Given this list of marker genes PIP4K2B, NES, CALD1, E2F7, TRAPPC2, ZPLD1, NUDT7, ATP11C, POLR3F (RNA polymerase III subunit F), TARDBP, SYNJ2BP, KHDC4, ZNF423, NHEJ1, ACSL6, SLC25A5, PAFAH2, BCL11A, SLC9A7, RTKN2, RETREG1 (NCBI Gene Id 96119), GTF2IRD2, P2RY10, CSMD2, MXRA5 (NCBI Gene Id 91006, matrix remodeling associated 5), EPHA6, ANLN, AGFG1, DENND6A, IP6K3, FAM168B, NCAM1, CHRNE, JARID2, SNX27, TRAK1 (NCBI Gene Id 22906), AFF3, CDC14A, RAB37, ELOC, ZFAND5, OGG1, OCM, DCLK1, NLGN1, SLC38A2 (solute carrier family 38 member 2), SHROOM1, C5orf24, GID8, IQCH, KIAA0232, HYCC2, KIF5C, DOCK3, SPOPL, TOGARAM1, RNGTT, GALC, ACLY, GPALPP1, HSPA9, SCAMP1, ATAD2B, USP15, IPO8, EIF4E2, PIEZO2, KDM4A, SYNGR2 (NCBI Gene Id 9144), IGF1R, SINHCAF, CTNNB1, EIF1B, CAMTA1, BTG1, ANKMY2, CELA1, NFAT5, GPM6A, ELP3, EPB41, ATP9B, WDR82, PICALM, SLC38A9, GATB, GFOD1, RAP2C, CKLF, SHISA9, MED13L (NCBI Gene Id 23389), TENM1, INO80D, SMC2, MED28, FIGN, RHOT1, ACBD3, OCM2, SLC25A38, EHD4, SLC1A1, POGLUT2, PPM1F, EIF5B, RAB11A (RAB11A, member RAS oncogene family), ARF6 (NCBI Gene Id 63379), CSTF2, ATXN7, CD200R1, MPC1, CCNJ, HACD3, G6PC1, GTF2IRD2B, COL6A6, CAMK2D, CCSER2, NOS1, TNFRSF19, SLC2A10, PSIP1, G3BP2, TMEM209, CIMIP6, GMFB, TMEM26, ANKRD50, TDG, SERTAD2, FGF2, GPR85, WDFY1, CORO1C, ZHX1, MGAT4A, PGRMC1, TNPO1, here is a description of the gene set: from publication Chen Y, Wang X (PMID 31504780) species: Homo sapiens Human Gene Set: MIR4418 Genes predicted to be targets of miRBase v22 microRNA hsa-miR-4418 in miRDB v6.0 with MirTarget v4 prediction scores > 80 (high confidence targets).